Given this list of marker genes Ero1b, Dpyd, Kdm1b, Aifm1, Mthfr, Foxred2, Nqo2, Aifm2, Mmachc, Acadsb, Ero1a, Acadvl, Pipox, Xdh, Acad11, Fmo1, Cry2, Dmgdh, Cyb5r1, D2hgdh, Cry1, Acads, Prodh2, Acox1, Fmo5, Nos3, Cybb, Ddo, Sardh, Fmo3, Mto1, Agps, Ivd, Txnrd3, Mical2, Nos2, Acad10, Acadl, Cyb5r4, Gfer, Pcyox1, Dhcr24, Txnrd2, Aox4, Kmo, Ndor1, Dld, Dus1l, Aox3, Maob, Sqle (squalene epoxidase), Aox2 (aldehyde oxidase 2), Etfa, Acox3, Dus4l, Gcdh, Aox1, Coq6 (coenzyme Q6 monooxygenase), Steap4, Ilvbl, Sqor, Chdh, Dao, Fmo2, Steap3, Cyb5r3, Por, Mical3, Acad9, Acox2, Cyb5r2, Mical1, Acoxl, Ldhd, Maoa, Dus2, Gsr, Fmo4, Acad8 (NCBI Gene Id 66948), Sdha, Acadm, Dus3l, Mtrr, Gulo, Prodh, Kdm1a, Txnrd1, Qsox1, Nos1, here is a description of the gene set: species: Mus musculus Mouse Gene Set: GOMF_FLAVIN_ADENINE_DINUCLEOTIDE_BINDING Binding to FAD, flavin-adenine dinucleotide, the coenzyme or the prosthetic group of various flavoprotein oxidoreductase enzymes, in either the oxidized form, FAD, or the reduced form, FADH2.